Given this list of marker genes GCNT1, SPDYA, SLC25A33, CSKMT, GPM6A, LHX8, STRN3, WDFY2, BIRC6, ZBTB14 (zinc finger and BTB domain containing 14), DNAJA4, NLGN1, FNDC4, TSC22D1, NUFIP2, TAOK1, PPM1B, SEC14L2, C8orf34, MAPK10, NDUFA6, NR2C2AP, SAMD9L, WDR7, FAP, SNRK, SEMA6D, NLK, NFATC2, CYP4A11, MUC17, CARMIL1, NSG2, TSPYL5, TNRC18, JAK1, RNF20, PPP6R3, CTDSPL2, CEBPZOS, HMX2, TMEM131 (NCBI Gene Id 55369), IMMT, MEX3C, SGK1, DNAJB14, C9orf40, SLC30A9, DMXL1, IL10, MTAP, ATP5MF-PTCD1, MTFR1, MBNL2, DTWD1, SKI, FOXC1, NF1, KIAA0930, here is a description of the gene set: from publication Chen Y, Wang X (PMID 31504780) studied in species Homo sapiens Genes predicted to be targets of miRBase v22 microRNA hsa-miR-552-3p in miRDB v6.0 with MirTarget v4 prediction scores > 80 (high confidence targets). Human Gene Set: MIR552_3P